The following is a description of a gene set: Reactome Pathway: Cooperation of PDCL (PhLP1) and TRiC/CCT in G-protein beta folding species: Homo sapiens The chaperonin complex TRiC/CCT is needed for the proper folding of all five G-protein beta subunits. TRiC/CCT cooperates with the phosducin-like protein PDCL (commonly known as PhLP or PhLP1), which interacts with both TRiC/CCT and G-protein beta subunits 1-5 (GNB1, GNB2, GNB3, GNB4, GNB5). PDCL enables completion of G-protein beta folding by TRiC/CCT, promotes release of folded G-protein beta subunits 1-4 (GNB1, GNB2, GNB3, GNB4) from the chaperonin complex, and facilitates the formation of the heterodimeric G-protein beta:gamma complex between G-protein beta subunits 1-4 and G-protein gamma subunits 1-12. In the case of G-protein beta 5 (GNB5), PDCL stabilizes the interaction of GNB5 with the TRiC/CCT and promotes GNB5 folding, thus positively affecting formation of GNB5 dimers with RGS family proteins. However, over-expression of PDCL interferes with formation of GNB5:RGS dimers as PDCL and RGS proteins bind to the same regions of the GNB5 protein. part of: Chaperonin-mediated protein folding, and this is the list of marker genes: GNG8, GNB5, GNG13, RGS7, RGS6, CCT3, CCT5, GNG3, GNG12, GNG11, CSNK2A2, GNG7, CSNK2A1, GNA15, GNAQ, CCT8, GNA11, GNG10, GNGT2, GNG4, CCT2, GNB1, CCT4, CCT7 (NCBI Gene Id 10574), CCT6B, GNG5, PDCL (phosducin like), GNG2, TCP1, GNA14, RGS9, GNB2, GNB4, GNB3, RGS11, CSNK2B, CCT6A, GNGT1